The following is a description of a gene set: Cervical ribs Human Gene Set: HP_CERVICAL_RIBS studied in species Homo sapiens, and this is the list of marker genes: SF3B4, IFT57, SF3B2, ANKRD11, GPC4, RUNX2, PDGFRB (platelet derived growth factor receptor beta), RBM8A, SON, AFF3, GATA6, ACTB (actin beta), GPC3, PUF60